The following is a description of a gene set: Human Gene Set: GOBP_MITOTIC_SPINDLE_ORGANIZATION species: Homo sapiens A process that is carried out at the cellular level which results in the assembly, arrangement of constituent parts, or disassembly of the microtubule spindle during a mitotic cell cycle., and this is the list of marker genes: TUBG2, ZNF207, CHMP4A, MAP4, INTS13, PLK1, POC1A, NEK2, INCENP, MYBL2, VCP, TBCE, CHMP2B, CHMP5, TPX2, POLDIP2, PLK2, CCDC66, AFG2B, WDR62 (WD repeat domain 62), CHMP2A, CEP97, CCDC61, KIF4B, SPC25, RAN, KIF3B, CDCA8, ANKRD53, RIPOR2, AURKB, LSM14A (NCBI Gene Id 91161), DYNC1H1, SBDS, PSRC1 (proline and serine rich coiled-coil 1), CEP192, KIF15, FAM110A, NUP62, UHRF1, KIFC1, CDC20, MISP, PRC1, KPNB1, KIF11, AURKC, DCTN2, FSD1, CHMP4C, MAP1S, PARP3, CHMP7 (charged multivesicular body protein 7), CLTC, HSPA1B, DLGAP5, CENPH, CHMP1B, TTK (NCBI Gene Id 7272), HNRNPU, SMC3, NUMA1, NDC80, ABRAXAS2, BORA, PIBF1, PRICKLE1, FLNA, SPAST, EML3, CCNB1, KIF4A, SPICE1, HSPA1A, RCC1, KIF23, CHEK2, PLK5, CLASP1, CKAP5, OFD1, CHMP1A, BCCIP, CENPJ, AAAS, RHOA, DCTN1 (dynactin subunit 1), EML1 (NCBI Gene Id 2009), TACC1, PDCD6IP, ILK, MAP10, GOLGA2, RACGAP1, NUF2, PCNT, NEK6, TACC2, CLASP2, STAG1 (STAG1 cohesin complex component), GPSM2, GNAI1, DCTN6, CHMP3 (NCBI Gene Id 51652), PLK3, MAP9, EFHC1, STIL, STMN1, CHMP4B, CEP126, RMDN1, CENPE, RANGRF, SUN2, CHMP4BP1, MZT1, ABRAXAS1, BIRC5, WRAP73, KIF2A, DRG1, ARHGEF10, TUBG1, RAE1, TPR, SMC1A, PKD1, SASS6, TNKS, NUDC, VPS4B, CCSAP, RAB11A, TACC3, AURKA, CHMP6, PTPA, STAG2